The following is a description of a gene set: studied in species Homo sapiens Any process that modulates the rate, frequency, or extent of dendritic spine morphogenesis, the process in which the anatomical structures of a dendritic spine are generated and organized. A dendritic spine is a protrusion from a dendrite and a specialized subcellular compartment involved in synaptic transmission. Human Gene Set: GOBP_REGULATION_OF_DENDRITIC_SPINE_MORPHOGENESIS, and this is the list of marker genes: SIPA1L1, BAIAP2, CDK5, EFNA1, ARC, CAPRIN2, ARMCX5-GPRASP2, CAPRIN1, SLC30A1, SHANK3, GPRASP3, LRP8, LRRK2, STAU2, RELN, NLGN1, NGEF (NCBI Gene Id 25791), PAFAH1B1, PPFIA2, PTPRD, ARHGAP33, KIF1A, SRCIN1, DTNBP1, EPHA4, TANC2, CFL1, PDLIM5, LZTS3, EPHB2, CDK5R1, ARHGAP44, CUX2, DBN1 (drebrin 1), ITPKA (inositol-trisphosphate 3-kinase A), IL1RAPL1, EEF2K, ABI3, ABI2, CAMK2B, ZDHHC15, DHX36 (DEAH-box helicase 36)